The following is a description of a gene set: Human Gene Set: GOBP_RESPONSE_TO_SYMBIOTIC_BACTERIUM studied in species Homo sapiens Any process that results in a change in state or activity of a cell or an organism (in terms of movement, secretion, enzyme production, gene expression, etc.) as a result of a stimulus from a symbiotic bacterium, a bacterium living in close physical association with another organism., and this is the list of marker genes: C4BPA, C4BPB, SLC22A5, GPX1, REG3A